Given this list of marker genes TXNIP (thioredoxin interacting protein), MORF4L2, CCNI, CLINT1, HNRNPM, G0S2, DNASE1L2, PUM2, PWP1, NNAT, NFKB2, RGS2, IFI16, EIF4H, ELK3, TJP1, DPM1, UGCG, ELOA, TP53BP1, PUM3, ESD, CAMK2D (calcium/calmodulin dependent protein kinase II delta), OGDH, MARCKS, CD164, CAST, EXOSC10, CEBPD, PKN2, MCL1, TOMM20, PSMA3, DHCR24, KANK1, SETDB1, ADCYAP1, RUBCN, S100A5, GTF2H1, H2AC6, ZFP36, RER1, TNFAIP3, PLIN2, RNF4, NUP188, ACAA2, RRS1, NOLC1, PRMT5, PITPNA, CBFB, ADM, ATIC (5-aminoimidazole-4-carboxamide ribonucleotide formyltransferase/IMP cyclohydrolase), CYP24A1, MKNK1, ATXN2, CDK7, FOXO1, AEBP1, RFTN1, GMFB, CES1, AARS1, RAD23B, CCND2, PSMA4, SRSF3, LSS, SLC39A14, ANXA2, RPS23, ARPC1B, DNAJB1, KCNC4, BZW1, CREB3, PHB2, TNFRSF1A, VRK2, WTAP, NOP14, RAB11A, FAM110B, DAZAP2, RBBP8, KLF5, PIR, PSEN2, NCAM1, CCT8, USP10, SERPINB8, NDRG1, PIGC, ARPC4, ECHS1, here is a description of the gene set: from publication Takao J, Ariizumi K, Dougherty II, Cruz PD Jr (PMID 11982916) Human Gene Set: TAKAO_RESPONSE_TO_UVB_RADIATION_DN species: Homo sapiens Genes down-regulated in primary tissue culture of epidermal kerationcytes after UVB irradiation. Ultraviolet B (UVB) radiation is an important inducer of many biologic changes in skin, of which keratinocytes are a key target. To gain better insight into changes in gene expression generated in the early phase after UVB exposure, we used complementary RNA (cRNA) microarray hybridization to compare differences in mRNA expression of UVB-irradiated (single dose of 100 J/m2 broad-band UVB) and sham-irradiated primary cultured human keratinocytes. Six hours after irradiation, total RNA was isolated from keratinocytes, and cRNA was synthesized and hybridized to a GeneChip expression array (Affymetrix) consisting of genes. Based on a threshold of > twofold change, genes (2.8%) were designated to be the most UVB-responsive. Surprisingly, none of these genes had been shown previously to be modulated by UVB. Conversely, several genes in the microarray that had been reported previously to be UVB- responsive by other methods showed less (< twofold) or no change. Northern blotting of seven differentially modulated genes produced results similar to those derived from microarray technology, thereby validating the accuracy of screening. Clustering based on known or likely functions indicated that among 88 upregulated genes, nine encode for cytochrome c subunits, six for ribosomal proteins, and two for regulators of apoptosis. By contrast, many of the 99 downregulated genes are involved in transcription, differentiation and transport. These findings indicate that keratinocytes respond to a single low dose of broad-band UVB irradiation by enhancing processes involved in energy production and translation, while suppressing those related to transcription, differentiation and transport.